The following is a description of a gene set: Human Gene Set: HP_DILATED_CARDIOMYOPATHY Dilated cardiomyopathy species: Homo sapiens Dilated cardiomyopathy (DCM) is defined by the presence of left ventricular dilatation and left ventricular systolic dysfunction in the absence of abnormal loading conditions (hypertension, valve disease) or coronary artery disease sufficient to cause global systolic impairment. Right ventricular dilation and dysfunction may be present but are not necessary for the diagnosis., and this is the list of marker genes: TCAP, SDHD, GLB1, SPEN, ACTC1, MYZAP, POLG, PPP1R13L, MLX, MT-TF (mitochondrially encoded tRNA-Phe (UUU/C)), LMOD2, TOP3A, RRM2B, ABCC9, FLII, SKI, SLC2A10, RRAGD, ERBB3, TNNC1, NUP107, PTPN6, TNNI3K (NCBI Gene Id 51086), RERE, DSP, XRCC4, VEZF1, ATP5MK, ACTA1, SYNE1, TWNK, MGME1, GATAD1, GET3, SGCD, MT-ND6, MMP1, XK, MYPN, MLYCD, ENPP1, MT-ND2, MEFV, PSEN1, KAT6B, POMT2, FHL2, CSRP3, MT-CO2, JPH2, PSEN2, ATPAF2, PRKCZ, BRCC3, SCN5A, MT-TK, BAG3, NAXD, MT-TS2, MYBPC3, BAG5, ALMS1, LAMC2, RBCK1, KCNAB2, LAMA4, SGCB, MYH7, DES, RRAGC, LMNA, DPM3, IL12B, CHKB, SLC5A6, ATP5F1D, COL7A1, HJV, TAF1A, TSFM, CASZ1, SPEG, BOLA3, SYNE2, HLA-B, MT-TQ, ACAD9, ANKRD11, ACADVL, LAMP2, ATP5F1A, UBR1, KCNJ2 (potassium inwardly rectifying channel subfamily J member 2), SGCA, MT-ND5, NEXN, CRYAB, GABRD, JUP, HMGCL, DSG2, ADCY5, TNNT2, ANKRD1, MT-TH, MMP23B, MT-CO1, TMEM43 (transmembrane protein 43), DEF6, GTPBP3, MT-TL1, MT-ATP8, TPM3, DMD, HSPG2, HAND2, ACAD8, HAMP, ADA2, HADHA, SDHA, DNAJC19, MT-CO3, FHL1, MT-TV, ACTN2, RAF1, HADHB, HCCS, PGM1, LDB3, PRDM16, TAFAZZIN, TRDN, MT-ND3, MT-ATP6, TTN, EPG5, MMAB, TPM1, SLC25A4, BBS2, CASQ2, FKTN, PDPN, LRP12, GATA5, VCL, EYA4, RYR2 (ryanodine receptor 2), VPS13A, MMACHC, KCNJ5, DOLK, COX7B, MYH6, RBM20, RNF220, FKRP, NDUFB11, LUZP1, UBE4B, TXNRD2, MT-ND4, PPCS, PLN, ATP5F1E, CPT2, LIMS2, HBB, MT-TW, LAMB3, TERT, RPL3L, MT-ND1, LAMA3, CAP2, HADH, TMPO, POLG2, MYL2, SLC6A6, TKFC, TNNI3